Given this list of marker genes MTHFD1L, SHMT2, GCH1, PCBD1, NOS3, FTCD, MTR (NCBI Gene Id 4548), PCBD2, SLC19A1, QDPR, MTHFD2, SLC25A32, AASDHPPT, MTRR, MTHFR, FOLR1, TYMS, ALDH1L1, SLC46A1, PM20D2, MTHFS, DHFR, DHFR2, FOLH1, ATIC, GGH, MTHFD2L, PRKG2, PTS, SPR, FPGS, SHMT1, DHFRP1, MTHFD1, ALDH1L2, here is a description of the gene set: studied in species Homo sapiens The chemical reactions and pathways involving any compound containing pteridine (pyrazino(2,3-dipyrimidine)), e.g. pteroic acid, xanthopterin and folic acid. Human Gene Set: GOBP_PTERIDINE_CONTAINING_COMPOUND_METABOLIC_PROCESS